The following is a description of a gene set: studied in species Homo sapiens Genes down-regulated in comparison of control dendritic cells (DC) at 8 h versus those stimulated with LPS (TLR4 agonist) at 8 h. from publication Amit I, Garber M, Chevrier N, Leite AP, Donner Y, Eisenhaure T, Guttman M, Grenier JK, Li W, Zuk O, Schubert LA, Birditt B, Shay T, Goren A, Zhang X, Smith Z, Deering R, McDonald RC, Cabili M, Bernstein BE, Rinn JL, Meissner A, Root DE, Hacohen N, Regev A (PMID 19729616) mouse primary BMDCs were stimulated with tlr ligands and gene expression changes were profiled on Affymetrix arrays Human Gene Set: GSE17721_CTRL_VS_LPS_8H_BMDC_DN, and this is the list of marker genes: TP73 (NCBI Gene Id 7161), SFTPA1, ELL2, SLPI, PTPRE, CLK3, PHGR1, OAS2, POP7, PITX1 (paired like homeodomain 1), TCTE1, TMEFF1, HMOX1, TSHZ1, MLLT6, MYT1, TBC1D13, SPHK2, EFHD2, CBLN1, DCTN4, DHX58, TMPRSS3, ARHGAP35 (NCBI Gene Id 79266), NECTIN2, AGT, HOMER1, POU2F2, ECE2, IER5, SOX12, SERPINI1, SAMSN1, SERPINB2 (serpin family B member 2), PHF13, IL17RE, ARF4, S100B, MPP1, REM2, RGL1, USH1C, PLEKHF2, ITPR1, GK, MAP3K5, TSSK2, RHOA, PDIA5, RPP25, LY6G6D, RAB3IP, ASB3, CEP350, ATOSB, GKAP1, SEMA3C, TRAF5, SPTSSB, APOC4, BLOC1S4, TNNT2, PDLIM4, CD82, KRTAP3-3 (keratin associated protein 3-3), DNAJC1, ELOC, FCAMR, METTL3, RUNX2 (NCBI Gene Id 860), GRHL2, NR5A1, PHIP, DDR2, MAU2, MTDH, IFNAR2, DDA1, VPS54, STXBP1, TIMP1, PSMC2, ATXN7L3, RNF41, DCAKD, PALLD, NDEL1, ARID5B, BIRC3, CPD, BCL2L1, KLHL13 (NCBI Gene Id 90293), COL4A2, PRG4, AOPEP, SOWAHC, KMT5A, CARD10, HMGN5, LDHC, SENP6, FURIN, TNFRSF1B, HINFP, PCP4, THNSL2, STAT5A, LGALS2, HKDC1, ABCG8, SLC32A1, PCDH8, JARID2, AMMECR1, SOCS1, TMEM39A, MC2R, SERTAD1, WDR54, CHODL, FKBP1A, CEL, PCM1, EML6, GTF2B, ANXA5 (annexin A5, NCBI Gene Id 308), ITIH3, B3GALT5, KAT2B, BMPR1A, ADAM21, PI4K2A, MDFIC, ZFAND3, PSMA4, ATL3, ERCC3, CCER1, PMVK, TULP1, CXCL6, FBXL14, HTRA2, GBP4 (guanylate binding protein 4), GNA13, RNF208, CCDC134, PSMB9 (NCBI Gene Id 92051), PPP2R2D, COA5, RAI14, OPN4, SPTB, PIP5KL1 (NCBI Gene Id 138429), LORICRIN, DUSP16, GJC2, NFKBIA, PPP2R1A (protein phosphatase 2 scaffold subunit Aalpha), MOCS2, RNF214, ANXA1, MAP3K8, ITGA4, HAPLN2, PKP4, ZNHIT2, G3BP2, DUSP2, HDAC1 (NCBI Gene Id 3065), ZNF426, CMTR1, CUEDC1, IRF8, TSC22D1 (NCBI Gene Id 8848), RILPL1, CAVIN2, SLC6A4, TAF5L, VPREB3, DDHD1, PMPCB, TCF4, FGF4, NR4A1, APBB1IP, CDH13, C19orf12, CAPN5 (NCBI Gene Id 7445), MMP14, PRPF38A (pre-mRNA processing factor 38A), PDLIM1, YIPF7, RPE, TCP10L (NCBI Gene Id 55264), MMP2, NCOA6, MRPL54, TMEM192